Given this list of marker genes IREB2, LCA5, TAB2, ATF7IP (NCBI Gene Id 55729), COX7A2L, GTPBP8, CSDE1, NADK2, ZNF696, PDE4D, RAB6D, NOX4, VSTM4, CNKSR2, ANO6, SENP7, B2M, CDIN1, RNF6, TCERG1, FAM237A, RTL4, TRDN, FBXO33, HERC4, KLHL42, NIN, INTS2, SRSF5, DSCC1, EFR3B, NCKAP1, RNF138, ZNF451, TRPM7, PER3, ELOVL4, FOXG1, ZC3H12C, WNK3, HNRNPA2B1, DNAJB6, TYW3, USPL1, ABHD18, SGCZ, BBS7, NOG, MAK, B3GNT2, GOLGA8M, GRPEL1, DIP2B, CHD6, STYX, TMEM97, NDUFB4, SMIM14, HAPLN1, SLCO2A1, NPR3, PPP4R2, TYRP1, AMN1, TMEM237 (transmembrane protein 237), GOLGA8N, SLITRK4, ADSS2, NUP50, CDH6, SPOCK3, NAIP, FOXD4L1, MON2, SLC38A4, CERS3, SLC35A1, SNX18, CAND1, RASSF10, POF1B, EMCN, RUFY4, SELENOI, ZFHX4, GRM5, NRN1, GNGT1, PHACTR2, WDR75, CLDN12, RALGPS1, MARS2, INPP1, SCG2, DPP10, PLXDC2, SV2A, ABCD2, SLX4IP, SH3GLB1, UBE2N, RASAL2, PIK3C2A, UBB, AFDN, TMBIM4, PSIP1 (NCBI Gene Id 93428), PNISR, NSMCE2 (NSE2 (MMS21) homolog, SMC5-SMC6 complex SUMO ligase), PUM2, GOLGA8Q, ZNF660 (zinc finger protein 660), BTAF1, ALDH9A1, CARNMT1, RNF2, ARPP21 (cAMP regulated phosphoprotein 21), GOLGA6B, CIAO1, PCF11, GRB14, MRPS18C, DMRTA2, THUMPD1, AHCTF1, TMEM33, EIF5A2, PYGO1, NEFL, C16orf95, ZYG11B, RRP15 (NCBI Gene Id 57241), CNOT6L, RBM39, RELL1, TNRC6B, YIPF5, NIFK, SCN3A, ADAM23, HNRNPDL, KLHL15, KIF4B, RTKN2, DACH1, SASS6, ANO5, CREBZF, NDUFB5, EIF4A2, ZNF131, NR3C1, DMRT3, CCDC141, ALG10B, LHX1, GOLGA6D, FOXN2, HYCC2, TLNRD1, FGFR2, UBA2, LZTFL1, PTPN4, CATSPERB, C2orf69, GALR1, FOXO3, UFSP2, DPY19L3, EML6, TNFSF11, MATR3, UBE2Q2P13, ZNF148, RRS1, MACIR, FBXL3, TEX12, DNAJC15, CADM2, FOXD4L6, ITPR2, GABRR2, IRF5, BMP2K, KLHDC1, MBTD1, TRIM13, PBX3, ST6GALNAC3, CSMD3, ATP6V0D2, TMOD3, IDI1, AZIN1, TRIB2, POU2F2, LACTB2 (lactamase beta 2), AKAP5, ZNF493, OSM, NSUN4, KMT2E, EYS, TMEM167A (transmembrane protein 167A), RPAP3, BLTP3B, PTP4A1 (NCBI Gene Id 7803), CADM1, CTNND2, C7orf57, GGNBP2, RNF11, AMMECR1, RPRD1A, TMEM132B, C12orf56, PIAS2, GPCPD1, MSL3, TPGS2, TMEM263, SOX11, ATP10A (NCBI Gene Id 57194), SLC30A8, IL5, SPPL2A, IDE, PWWP2A, LEPROTL1, ZFP36L1, RNF103, KCNJ16, NAA25, FZD4, ADD3, ANKRD26, BLOC1S4, SPTBN1, SLC44A5, RAB6C, KLHL8, CEBPG, TSPYL5, PDS5A, NT5DC1, KLHL5, SERINC5, NHSL3, TGOLN2, ONECUT2, MAP3K2, EDNRA, GOLGA8H, LGALSL, GCK, ZBTB21, CDH2, NFAT5, CER1, ETNK1, ADGRG2 (NCBI Gene Id 10149), SAMD8, PANK1, CHL1, SANBR, SMIM8, MACROH2A1, DDX3Y (NCBI Gene Id 8653), KLHDC10, ZBTB43, UBQLN1, ZNF519, WASL, AQP4, TMED5, UBE2W, NSUN6, BHLHE40, GRIK2, KIF4A, IFT81, LIFR, EPS8, FGD6, SRSF2, SETD3, OSER1, CXCL2, BEND6, INSIG2, PLSCR4, USP33, SORCS1 (NCBI Gene Id 114815), SLC2A2, GNB1, DCP2, ZFPM2 (NCBI Gene Id 56958), ATP6V1B2, GPHN, CCDC6, NEXMIF, B4GALT6, CLPX, ZNF800, BCL11A, TNPO1, SLC10A7, SLC7A11, DLX3, ERBB4, MDFIC, PEX19, CCL2, MKLN1, CACNB4, PRDM11, CREBRF, CGGBP1, SNX16, HNF4G, RBL2, MRFAP1, GOLGA8R, POC5 (NCBI Gene Id 134359), KIAA0753, KCNJ2, FMR1, B3GNT5, ZNF319, KANSL2, CEMIP2, GOLGA6C, ID4, ETV1, GCFC2, CASP7, ADCY1 (adenylate cyclase 1), KCNN4, LRCH2, GAPVD1, PWWP3B, MTMR6, SPRY3, MAP1LC3B, FIGN, DCUN1D1, RAP1B, ZNF28, AKAP6, POT1, FOXD4, MLF1, FGF12, NCAPG2, SIPA1L2, A1CF, HECA, ZIC3, HMGN5, RNF180, OSBPL8, RUNDC3B, PAPOLA, PLSCR5, GDAP2, GOLGA8J, RAB30, PREX2 (phosphatidylinositol-3,4,5-trisphosphate dependent Rac exchange factor 2), WLS, GOPC, HSPA4L, OSGEPL1, KDM4D, TTC21B, TWF1, PCDH9, SBF2, MBNL3, SNTG1, ENSG00000286190, ZNF302, CHML, PIEZO2, STK17B, AVIL, GPAM (NCBI Gene Id 57678), ZNF260, RNF212B, CMKLR2, LIN9, AGFG1, CTSS, DMC1, SFR1, HIPK1, CACNB2, ATP2C1, AHCY, RBM46, WDR43, TMEM243, CALHM5, BPNT2, MINDY2, SCAI, RBM47, FBXO21, GPR82, ARHGEF33, INTU, PDHX, LCOR, AMER2, LATS1, TBL1XR1, KCTD8, MND1, UBR7, DMXL2, DNAJC27, GLS, FOXD4L3, HEBP2, ZNF280D, SIX4, STAM, MROH8, ACVR1C, HDHD2, CREB1, FAM91A1 (family with sequence similarity 91 member A1), PCSK6, GOLGA8T, LATS2, NUDT12, LURAP1L, PRR15, HACD3, GLT6D1, RTN1, CXCL14, ARHGAP18, TAF1A, ZEB1, COL14A1, FCHO2, ISOC1, CCDC85A, ELOVL2, CYB5R4 (NCBI Gene Id 51167), PCDH7, MBNL1, ARHGEF10, SPRED1, RAB6A, KAT6A, ABRA, ARF6, FAM117A, DCUN1D4, LMBR1 (limb development membrane protein 1), ERCC3 (NCBI Gene Id 2071), NRARP, here is a description of the gene set: Human Gene Set: MIR3143 studied in species Homo sapiens Genes predicted to be targets of miRBase v22 microRNA hsa-miR-3143 in miRDB v6.0 with MirTarget v4 prediction scores > 80 (high confidence targets). from publication Chen Y, Wang X (PMID 31504780)